Given this list of marker genes GMPPB, RXYLT1, TUBB3, B4GAT1, POMGNT1, B3GALNT2, CRPPA, FKRP, POMGNT2, FKTN, LARGE1, POMT2, POMK, TMTC3, POMT1, LAMB1, here is a description of the gene set: studied in species Homo sapiens Human Gene Set: HP_TYPE_II_LISSENCEPHALY A form of lissencephaly characterized by an uneven cortical surface with a so called 'cobblestone' appearace. There are no distinguishable cortical layers. Type II lissencephaly